Given this list of marker genes PUS7, RPUSD3, TRUB1, RPUSD4, PUS7L, TRUB2, DKC1, PUS3, RPUSD2, PUS1, here is a description of the gene set: The intramolecular conversion of uridine to pseudouridine in an mRNA molecule. species: Homo sapiens Human Gene Set: GOBP_MRNA_PSEUDOURIDINE_SYNTHESIS